The following is a description of a gene set: Genes negatively differentially expressed in cell type: NK cell upon treatment with cytokine: IL-30 in mouse lymph nodes in vivo. from publication Cui A, Huang T, Li S, Ma A, Pérez JL, Sander C, Keskin DB, Wu CJ, Fraenkel E, Hacohen N (PMID 38057668) species: Mus musculus Cytokines mediate cell-cell communication in the immune system and represent important therapeutic targets. A myriad of studies have highlighted their central role in immune function, yet we lack a global view of the cellular responses of each immune cell type to each cytokine. To address this gap, the authors created the Immune Dictionary, a compendium of single-cell transcriptomic profiles of more than 17 immune cell types in response to each of 86 cytokines (>1,400 cytokine-cell type combinations) in mouse lymph nodes in vivo. A cytokine-centric view of the dictionary revealed that most cytokines induce highly cell-type-specific responses. For example, the inflammatory cytokine interleukin-1β induces distinct gene programmes in almost every cell type. A cell-type-centric view of the dictionary identified more than 66 cytokine-driven cellular polarization states across immune cell types, including previously uncharacterized states such as an interleukin-18-induced polyfunctional natural killer cell state. Mouse Gene Set: CUI_NK_CELL_IL30_RESPONSE_DN, and this is the list of marker genes: Klf2, Rgs1, Junb, Btg2, Fos, Jun